Given this list of marker genes CARD8, SIRPD, NUCB1, ATP10D, FAM72D, CDKN1A, ESRRA, ZNG1B, ANXA5, RNF19B, RNU7-45P, LRRCC1, TMEM229B, HTATIP2, PTGES3P1, CATSPERG, GLRX, SLA, NLRP3 (NCBI Gene Id 9558), AKR1A1, WSB2, AP1M2, PARP4P2 (poly(ADP-ribose) polymerase family member 4 pseudogene 2), JMJD1C, TMEM51, MXD3, ADGRE5, TCAF2, MBD2, HAUS4, NTNG2, CARD6, EPSTI1, MIX23P1, ADAP2, GK3, SLC7A7, STARD8, CD14, SCML1, TM9SF2, CREM, ST8SIA3, FZD5, LILRA5, TMEM59, CLASRP, GRIN3A, CNTLN, MIR4632, NSL1, ARSL (arylsulfatase L), USP15, CLEC2B, FAM72A, PDK3, CYBB (cytochrome b-245 beta chain), SERPING1, DNM1P33, OR56B1, INTS3, SIK3, SIL1, AFF2, ERAP2, NGFR, STX4, SLC22A16, CALR, HERC6, DUSP10, EPB41L3, KIF9-AS1, OR52V1P, RMC1, NUCB1-AS1, STAM2, STOM, MED28, NT5C2, CICP19, FGL2, COPG1, NEU1, SH3BGRL, SCYL3, SLC31A2, STN1, MIR4433A, RAB43, NMT1, NIT1, TMEM154 (transmembrane protein 154), RNF13, CD68 (NCBI Gene Id 968), SPAG6, ISOC2, GAS6, MYL12A, PRPF4, TMEM140, SRA1, XAF1, MIIP, DLEU2, PLSCR1, FAM20C, TAB3-AS2, ACSM1, RUFY3, PML, ZSCAN16, OSMR, MCL1 (NCBI Gene Id 4170), MBOAT1, EGLN1, PAEP, MITD1, MAX, NECAP1, C1GALT1, SLC52A2, ASGR1, SYNGR2, PPP4C, SHOC2, NT5C3AP1, BACH1-IT2, LILRA6, MCTP1, CD33, IFNGR2, RAB39A (RAB39A, member RAS oncogene family), CTSL, DDX60, BCL10, CD300A, ARAP2, CHSY1, UBE2D3, RNF138, PRPS2, SLC22A1 (NCBI Gene Id 6580), RPL7P53, SLC1A3, C21orf91, FBXO6, KCNJ2, CXCL16, STX17, MR1, CD86, POLDIP3, HSPA7 (heat shock protein family A (Hsp70) member 7 (pseudogene)), TOMM40L, SLC44A4, DIP2B, CXCR1, TBK1, PTPRU, NKIRAS2, UBQLN4P1, TMEM131, SLC37A1, PLEKHA2, SLC17A8, PHF11, JUNB, TFE3, FHIP2A, TNFSF15 (TNF superfamily member 15), MTND4P14, NBN, RAB20, SLC43A2, OR2W6P, KIAA0319L, LSP1, SLC25A24, MGAT1, IFIT1, HMOX1, SHISA5, SPATS2L, ICAM2, RPS19P3, PLAGL2, WDFY1, CPED1, IFI44, EIF4E3, TLR3, ARMCX3-AS1, GRB2, OSTM1, ARPC1B, HNRNPA1P53, FAM225B, PHACTR2, BCL2L14, BRCA2, ERV3-1, FCGR2C, UBE2SP1, CD59, GOLM1, FTL, HES4, KCTD5, OGFR, CENPCP1, TGIF2, HK1, AAMP (NCBI Gene Id 14, angio associated migratory cell protein), MIA3, SIGLEC5, AKIRIN2, WSB1, CIR1, TIGAR, IL27, CARD17P, CEACAM1, DNAJC7, TMEM164, CARD16, ISG15, HMGB1P3, GPR42, MEGF11, GPX1, SPHK1, EIF2AK2, SNX11, LYRM1, UNC93B7, KCNMB1, USP6NL, VCAN-AS1, RGS19, PLXNB2, CDC73, SMARCD3 (SWI/SNF related, matrix associated, actin dependent regulator of chromatin, subfamily d, member 3), TOR1A, FGR, SIGLEC11, P2RX4, CHMP1A, SNORD56B, SAMD15, PSTPIP2, RTCB, TEP1, NMI, HNRNPLL, LRRK2, SH2D3C, RNVU1-1, REEP3, ALDH2, SH3RF1, CXCL9, SYNPO2, OOSP1, MNDA, LINC00528, OR7E100P, RNU5A-5P, SH3GLB1, JSRP1, QKI, IFI35, PRPF40A, IRF1, DPRXP2, B2M, C5orf58, IL17RC, BAZ2A, LAMP3, LAP3P2, SBNO2, ANXA2P2, TTC38, SLC5A9, MVB12A (multivesicular body subunit 12A), ELMO2, NT5C3A, DENND1A, C2orf66, CXCL11, MICA (NCBI Gene Id 92319), CIBAR1, MX2, WDR45, GUCY1A1 (guanylate cyclase 1 soluble subunit alpha 1), LMO2, RILPL2, CD300LF, SCARNA22, UBR2, PLEKHM2, AGBL5, SMIM10, ZNF804A, FGF13 (fibroblast growth factor 13), CDH6, PFKP, PIM2 (Pim-2 proto-oncogene, serine/threonine kinase), CCDC149, PTPN6, ZNF366, LTBR, IRF8, SRD5A1 (steroid 5 alpha-reductase 1), RCC2, DOCK8-AS1, TLR2, LINC00937, H3P6, CHMP2A, LPIN2, ANKRD36BP1, ZNF618, SLC2A3P2, SLC49A3, BIN2, SRGAP2C, PHLPP1, DMXL2, LINC00487, TCIRG1, SLC22A15, RNH1, TRIM44, SAMD9L, TMEM123, CLEC5A, SP100, KLF5 (KLF transcription factor 5), TNF, SUCNR1, RPS6KA4, CTSA, HCP5, ZDHHC5, NLN, IDH3G, RTL5 (NCBI Gene Id 340526), IFNK, CD1D, C2orf80, DERL1, TREX1, MAPKAPK3, ERICH6B, RCBTB2P1, PDIA6, ANXA4 (annexin A4), FEM1C, CSNK1G2, TAF8, DCLRE1C, RIPK1, TIPARP, CADM4, C6orf62, OR52H1, GBP4, JUND, TCF7L2, CYTOR, SLC27A3, EFCAB2, NCF1, NOD1, TMEM179B, APOBEC3G, ATP1B1, C5, OR52U1P (NCBI Gene Id 81243), AOAH, IFT56, RAB3GAP1, KMO, ARRB2, FMR1, MYCBP2-AS1, DUSP5, GIMAP6, TPM4P1, C1QB, CSF2RB, NAPA (NSF attachment protein alpha), TNFSF10, GORASP1, CYB5R4, FCN1, NCF1B, BATF2, IRF7, PSMB8, NRDC, MPEG1, HLX, IREB2, RAB10, CUL1, RHBDL2, PLSCR4 (NCBI Gene Id 57088), RN7SL124P, TRIM64EP, ANKRD22, FUOM, TIPRL, ZBTB7B, APOL3, KCNE3 (NCBI Gene Id 10008), DHRS12, ZNF496, UBE2L3, ARL11, DDX60L, CD74, TNFRSF1A, PELI1, CACNA1E, UNC93B1, CAST, AIM2 (NCBI Gene Id 9447), C1GALT1C1, OR52T1P, KLF4, EDEM2, ATP5F1B, PRKCE, LARP4B, CIMAP1B, LIPM, IFITM3, CYRIB, GM2A, GNG5, MSRB1, CCDC170, PLA2G7, RPS6KA5, TRIM69, CMTM6, SLIT2, ZNF702P, RPL5P23, RCN1P2, PARP10, UBQLNL, MT2A, FCGR2A, AGRN, FUNDC2P4, UBE2V1P6, EIF5A, MIR5685, TUBA1A, FAM241A, RPL37P1 (NCBI Gene Id 140696), MIDN, SIPA1L1, ATXN7L3, STAT2 (NCBI Gene Id 6773), GSN, OSBPL5, RN7SL368P, PRR16, SLC43A3, GCNT2, PRELID1, KLHDC8B, FAM72C, PLAC8, SH2B2, MPZL1, LIMK1, ANKUB1, SETP11, SCIMP (NCBI Gene Id 388325), KRT18P4, NETO2, SLC26A8, RPS6KC1, SLC22A4, HBG2, SIPA1L2, TMOD2, PSEN2, PSMA4, ADPRS, GK, ATP6V0E1, RFX5, RHOQ, IL12RB1, FCGR3A, ACLY, TLR4, TOX4, FMNL2, VWA3B, CERS6-AS1, RNA5SP201, IRF9, PKN2, CHN2, RIF1, BTN3A3, TMEM106A, MYOF, LPCAT2, MOV10, PSENEN, ZNF684, H2BC18, BLTP1, IL1RN, CEBPB, PIP5K1A, DHRSX, NFIL3, SCO2, ATP6V1E1, NIPA2, DDAH2, BAK1P1, NIBAN2, STK3, LMNB1, PLAAT4, ALPK1, NPC2, PTK2B, DECR1, GRAMD1B, YKT6 (YKT6 v-SNARE homolog), GNB4, PLA2G4C, MTMR4, TMX1, RNU6-890P, CFB, SAT1, AIF1, BTN3A2, STX10, DDX21, RALB, C3orf38, SORT1, NCF1C, CLK3, BAK1, PRKCD, CEP162, RN7SL600P, EIF4H, CASP7, MXD1, LACC1, DPF2, POLB, PSMA5, POMP, SYCE3, NRAS, HDX, LYZ, GUCY2F, CBR1, RNU7-40P, RRAS, RELT, ILK, LCP2, HPS5, ARCN1, BRD7, PRDM1, TNFSF13B, H3-3B, TRIM6, CCL8, RIPK3, SCO1, IL12A, IFIH1, GPS2, PTPN1, KPNB1, CD46, DNAAF1, ENDOU, AOAH-IT1, ADAR, APOL1, DNAJC15, LHFPL3-AS1, RAB11FIP4, BMAL2, TNFAIP2, ARHGAP26, MIR103A2 (NCBI Gene Id 406896), H3-5, OAS2, ERAP1, LY6E, REC8, ATF3, SH2B3, RNU4-41P, SCAMP2, GAPDHP14, MTMR14, AP2S1, TMEM219, TIMM10, SOCS1, PDIA3, HLA-H, FAM120A, RIGI, ATP6V1C2, MAPK14, WARS1, ZNF117, XPNPEP1, GNA13, SRC, TBC1D1, DZIP1L, FYTTD1, HLA-DRB1, CYLD, TSPAN17, NDUFA9, LGALSL, DNPEP (aspartyl aminopeptidase), CYTH4, NIPSNAP3A, ACO1, ZNF710 (NCBI Gene Id 374655), RN7SL435P, C3, C3AR1, STAB1, MFSD2A, CAPNS2, SMIM14, ZNRF2, TAFA2, SASH1, HAPLN3, H1-6, RAP1AP, MAN1A1, SAP18, RNF24, FMR1-IT1, H4C14, MIR142, AP1S3, TLDC2, SLC6A12, PLET1, SERPINB9, TOR1B, RSPH3, SNAPIN, DNAJB12, PIK3AP1, CASP4, TRAPPC3, MIR1827, RPL28, TSPAN2, RNU6-613P, RNA5SP449, CDK17, SCARB2, MOB1A, EXT1, CYFIP1, CMKLR1, RN7SL440P, GBP3, GRIPAP1, SPATA13, GNS, IFI27, TMEM268, ORMDL2 (NCBI Gene Id 94102), FLVCR1, DDO, STAT3, KARS1, RALY, PRLR, FRMD3, MIR4679-2, NDC80, FAR2, SQLE, PI4K2B, AFF1, KIF13A, ATP6V1B2, TMEM144, IRF5, HHEX, NAT8, AGPAT3, MIR4645, CFP, STYXL1, DEGS1, ARF1, SIGLEC14, TYROBP, ELF1, STAT1, IDH1, RBBP6, PPARGC1B, ETV6, RBMS2, HLA-A, MTND5P14, IFIT2, TMEM252, DNAJA1, MS4A14, VRK2, UQCRC1, ITPRIP, PSMB4, C15orf39 (NCBI Gene Id 56905), RBM43, LYPD5, BRI3, CHRNB1, SECTM1, SCARF1, SDE2, ABCA1, FANCA, RAP2C, CD209, DUSP3, ADAMTSL4, MTND1P11, METTL4, SEMA4A, CMC2, RN7SL364P, UBE2J1, MRPS21P2, SPATA1, USP25, USP2, RTN1, FAM225A, PRRG1, CHRNA6, CCNA1, ATOSB, MAP3K11, SLC51A, JAK2, DDX10P1, GASK1B, FNIP2, CHD1, PRRG4, RP1L1, ARHGEF10L, MTF1, ERICH3, BTN3A1, FCN2, RAB8B, DEK, GTPBP2, ARR3, PSMB2 (NCBI Gene Id 5690), CHRNB2, PIK3CD-AS1, RN7SL473P, HSPA8P5, SERTAD3, KIAA0040, MIR320E, BLVRA, CLIC1, TRIM56, KIAA0930, CYBA (NCBI Gene Id 1535), NRN1, TBC1D22A, FLOT1, VASP, NRBF2P4, RCSD1 (RCSD domain containing 1), YME1L1, SMAD1, LGALS17A, GIMAP4, SUPT4H1, SUSD1, WASHC4, DAPP1, FAS, EPHB1, NPTN, GVINP1, RAB8A, IDH3A, SELL, CLIC4, TOP1, EXOC6, FZD2, RNF185-AS1, ZBED1, NRBF2, PPM1K, SLU7, COMMD9, RAC1, BACH1, GIMAP2, MPV17L2, RBBP8, PSMD3, FOXN3-AS1, SCPEP1, MFSD14B (major facilitator superfamily domain containing 14B), TIMELESS, SYT9, STK40, CHGA, MTG2, NUP205, MOB3C, PRKAR1A, NXT2, IDH2, UPF3AP3, EVI2B, TNS3, DNAJC1, RTN2, RIN2, MTHFD2, SQSTM1, ZBP1, SAMD4A, SLFN5, LIF, FGD6, WASHC2C, ASPHD2, SLC25A28, PRELID1P1, PARP14, RCN1, RERE, ARHGAP27, DYNLT1 (dynein light chain Tctex-type 1), ADM (adrenomedullin), SFT2D2, PTGR1, NDUFV1-DT, PPP2R2A, NCKAP1L, KIF1C, HLA-DPA1, ACOD1, PHC2, CPPED1, MAP3K13, FPR2, RNF135, RNASE2, DNAJB11, DRAP1, VPS9D1, UBFD1, NAMPT, SNX10, PANX1, LMTK2, CELF2-AS1, CTSB, RO60, DPYS, IGSF6, ANXA3, MAT2B, SIGLEC16, MED12L (NCBI Gene Id 57726), PABIR3, RPL3P6, ARK2N, CLEC4D, DESI1, LIPK, KCNE5, ITPRID2, OSM, CCL13, IDO1, RNF144A, COQ10B, CHMP2B, WDR41 (WD repeat domain 41), SH3TC1, SLC35A4, EWSR1, SMCO4, WDFY3, BTN2A2 (NCBI Gene Id 10385), NASP, MARS1, RHBDF2, PRTG, DISC1-IT1 (NCBI Gene Id 104472714), THA1P, STAC3, RNU6-810P, C1QA, TATDN2P2, TXLNB, ADA2, SLC35A5, PRCP, SFT2D1, ZSWIM6, TGM2, PLXDC2, PSME1, DTNBP1, IL31RA, GRN, MLKL, DHX58, VRK3, PSMB9 (NCBI Gene Id 92051), ZNF438, TRIM26, TCN2, MTMR11 (NCBI Gene Id 10903), SP110, RHOT1, LIMK2, ANXA2, STK24-AS1, INAFM1, SCLT1, DRAM1, MIER1, SDC3, CYP2J2, TFG, NUB1, ETV7, OTUD5, DLC1, FYB1, CLCN5, GDI2, IGF2BP3, HCK, LINC00623, FNDC3A, GARIN4, FIG4, TAGAP, ANXA10, GBA1, HSPA6, SERPINB1, SP1, FAM20A, LILRB4, BAZ1A (bromodomain adjacent to zinc finger domain 1A), CCDC73, MIR4511, AIG1, PCGF5, CCSER1, CDKL5, CTRL, CES1, PRMT5-AS1, HIGD2A, JPX, TIMM17B, MTHFD1 (NCBI Gene Id 4522), UBTFL3, SNF8, TNFAIP6, GBP1P1, IL2RG, PDE4B, USP41P, ALDH1A1, EMP3 (epithelial membrane protein 3 (MAM blood group)), TMEM62, NCOA3, CNTD1, IL15, ADCY7, FUT4, PRDM5, ACTR1A, GAK, OR10AA1P, CLDN18, PMAIP1, CCDC97, PLEKHN1, HBP1, KREMEN1, ZNF672, PARP9, ACSL4, C14orf93, IFI44L, SLAMF8, PSMA6, NRIP1, SNX20, HSPB9, IFIT5, CD36, MIR4435-2HG (MIR4435-2 host gene), LOXL3, SCRN3, ACOT9, PRR11, LHFPL2, CYC1, AGPAT5, VDR, CHMP4B, RBM7, TXNIP, CFAP58, LILRB5, ABCD1, GPD2, DPYD-AS1, ACSL5, TJP2, KDM1B, COPE, HTR4, TFEC, EXOSC9, CYBC1, ARFIP1, GRK3, NUP58, MFSD14A, WDFY3-AS1, C9orf72, TINF2, SLC31A1, CFLAR-AS1, ZEB2, GPR141, NADK, COP1, SPART, SLC12A8, CLEC7A (C-type lectin domain containing 7A, NCBI Gene Id 64581), NHSL1, P2RY12, ERP29, PSMD6-AS2, LOXHD1, XIAP, EXOC3L1, PRR29, MANBAL, CERKL, WASHC2A, DCAF11, ANO5, CPVL, LINC00534, ATG3, RNU4-24P, CD38, UTRN, MX1, ATP6V0D1, C19orf38, BATF3, NCEH1 (NCBI Gene Id 57552), BNIP5, RASGRP3, DOK1, LINC00877, SNX6, TXN2, GLUL, ADPGK-AS1, KIF1B, GBP1, IFITM2, BIN3, EFHD2, CDH23, CCRL2, DYSF, DDX3X, SMAP2, TPP1, SLFN12, CDKN2D (NCBI Gene Id 1032), ZNG1C, PRMT5, SRBD1, MSL3, CMAHP, AMER1, HK3 (NCBI Gene Id 3101), SNTB1, LMO4, PRKAG2, STOML1, SDSL (NCBI Gene Id 113675), GPBAR1 (NCBI Gene Id 151306), FLI1, CLCN7, MICALL1, HERC5, ORAI2, ICAM1, NLK (nemo like kinase), PANK2, PARP4, DHX8, VAV1, UBE2F, SRP54, PBLD, CBX1P4, HLA-G, RSPH9, CALM3, PLPBP, SSB, PDCD1LG2 (programmed cell death 1 ligand 2), APLP1, MAGT1, NABP1, PLSCR2, ZFP36 (ZFP36 ring finger protein), LGALS1, MDK, GIMAP8, GPBP1, MILR1, BMPR2, RAB1A, ZNFX1, TAPBP, SOWAHD, SLC25A30, TPM3 (tropomyosin 3), RAB33B, EDEM1, MTND6P5, GMFBP1, ZCCHC2, CACNA1A, NFE2L3, JAK3, PPTC7, TAP2, PRKD2, H4C15, STARD4, NINJ2 (ninjurin 2), SESTD1, FKBP15, UBE2E1, USP18, IRAK2, ROGDI (NCBI Gene Id 79641), CD163, TMEM165, CD2AP, PAIP1P1, HELZ2, MS4A4A, SLC16A3, EPS15, FAM111A, CAPZA2, PNPT1, RASSF5, COA6, HLA-C (NCBI Gene Id 5674), N4BP1, SCYL2, BTK, NOD2, GK-AS1, CHST7, RAB12, EMILIN2, PRUNE2, ZNG1F, RAB5A, NCOA2, STK32B, MS4A7, JUP, EPG5, UBA7, CENPN, SP140, CPEB3, BECN1, HSH2D, OR52K1, TENT5A, NAGK, SPG11, PLS3, TOPORS, LRRC59, NLRC4, H2AC6, IL1B, H3P36, ACP2, MIR3150B, ITGA4, DBF4B, HAVCR2, FAM135A, NME8, ST8SIA4, DHTKD1, SPG21, GCH1, CNIH4, HSPA1B, CCR1, CD300E, RNY4P18, SCIN, HIF1A, SDHB, GTPBP1, SUMO1P4 (NCBI Gene Id 101290502), IFIT1P1, PPCDC, KLHL6, LYN, ZC3HAV1, FOXD4L4, ATP6V1G1, NAPSB, MIR4477A, CDKN1C, NANS, HCG27, STX3, TBC1D20, OR52K2, TNFRSF14, DPYD-AS2, NUP62, SCAF11, CTSZ, BBX, TRIM38, KCNH7, USP30, EHD4, OTUD4P1, MTPN, RUBCN, EFR3A, TMEM150B, FOXL2, GPR84, HBEGF, RNU6-1294P, ARSD, KCTD14, PSMC1P4, PTTG1IP, DAZAP2, ADCY4, NUDT16, APOL4, MED13, NFAM1, IFI30, APOL2, FRMD4B, GPR155, PLEKHB2, HIRA, MRPL44, VSIR, CCDC200, KIF5B, GNA15, KDM2A, C5orf15, OR52B4, ARHGAP31, RNF31, TBC1D2B, IFI6, ATXN7, RN7SL382P, CES1P1, RN7SKP17, NFKBIA (NFKB inhibitor alpha), HLA-DPB1, ILRUN, CARS1, SAMHD1, CYB561, IER5, TTC21A, FCGR1BP, TRPC4AP, KCNS2, PEF1, LAG3, UBE2L6, TMEM199, FARP2, ME2, BID, MFSD5, ARSB (arylsulfatase B, NCBI Gene Id 411), ISG20, CDC42EP2 (NCBI Gene Id 10435), MTND5P28, H2BP1, RESF1, ASPRV1, TAF10, KBTBD2, CIITA, KIAA1958, IDO2, CXCL10, FOXN2, HEBP1, PHF23, TMOD3, RNASEL, MSR1, VAMP3, GALM, PLEK, PCK2, TRAFD1, CD300C, TGM1, MRPS18A, ZDHHC4P1, BTN2A3P, GNB2, TATDN3, EYA1, CAPZA1, C19orf12, GYG1, SMTNL1, CCL1, PAK1, CST3, POLA2, SIK1, SETD7, RAB5C, NFKBIE, COPZ1, TOR1AIP1, MAD2L1BP, RNU6-1082P, FCGR1A, ELOVL5, MATCAP1, LAT2, NOP10, TIFA, OASL, GART, SAMD9, TMED7, CCDC154, COX6B1, NAGA, PBX2, CNP, VMP1, RNF114, FAM8A1, PIPSL, TUT7, GCNT1, SIGLEC1, EMP1, HSPA1A, SEC24D, LAMP2, GLIPR2, STS, RIPOR2, PTPA, CLEC4E, KANSL1L, SERTAD1, GABARAP, VAMP5, PIGB, APOBEC3B, CMPK2 (NCBI Gene Id 129607), SLK, IER2, OAS3, HESX1 (HESX homeobox 1), ZNG1E, THEMIS2, SNORA51, LIFR, CALHM6, FAP (fibroblast activation protein alpha), MSRB2, TASL, CD53 (NCBI Gene Id 963), ECPAS, LILRA1, DTX3L, PPP1R11, DISC1, TNFAIP3, OR52K3P, TRIM27, HLA-K, AURKAIP1, ADPGK, TRIM22, IL17RD, ZMYM4-AS1, MT-TS1 (mitochondrially encoded tRNA-Ser (UCN) 1), WDR64, STAT5A (NCBI Gene Id 6776), SLITRK4, CLEC1A, SRGAP2-AS1, RNASEH2B, FIBP (NCBI Gene Id 9158), CCDC9, RNASEH2B-AS1, RANGAP1, TBC1D8, TESK2, TMSB10, STARD3, MRPL17, SH3BP2, GSTK1, DNTTIP1, ARHGAP25, PTP4A1, MAP2K6, ATF5, SRGAP2B, HIVEP1, GBP6, DHRS9, CNTRL, ST3GAL5, SFRP1, CYSTM1, RHOG, PSMA3, LSM10, KYNU, DEDD2, FFAR2, PLIN3, CALM2P2, ZNF267, IFI16, CHMP5 (charged multivesicular body protein 5), CORO1B, UNC93B2, KAT5, ATF6, TANK, HELB, MS4A6A (NCBI Gene Id 64231), CAPN2, GTF2F1, RMI2, GMPR2, PIWIL4, ABHD16A, CASP5, IL13RA1, CGAS, RBCK1, CICP3, RTP4, APOL6, BROX, UBE2S, DIAPH2, RTEL1P1, RNF169, ECE1, HLA-DMB, FOLR2, MYCBP2, STAU1, PTPRE, LAPTM4A, PRDX1, LDLR, KCNJ15, ADPRH, CSF1R, STIMATE, MPDU1, RNA5SP39, CCL2, TRIM25, ZDHHC19, DOCK4, SLC37A2, CEP164, CCDC146, SETX, AP3B1, CTBS, CREBRF, TAP1, YIPF1, SASH3, RNU6-147P, SLC44A2, RSAD2, HLA-B, ZC3H12A, LMF2, EIF4A1P7, PTGS2, LGALS9, TMEM121B, PLAGL1, RN7SL587P, CAMK2D, CTNNA1, P2RY13, RELB, RAB24, UBE2CP1, ATP1B3, CCL7, DLEU7, MRPL16, SCG3, PSAP, USP30-AS1, SPSB1, ZDHHC18, CASP1, SQOR, SHOX2, MFSD13A, UBN1, PUS3, DUSP1, VCPIP1, IFITM1, LINC00968, LGALS3BP, LATS2, GK-IT1, MEFV, CFAP58-DT, GSDMC, TMEM30A, SLC9A8, RNU6-748P, CARINH, NAB1, SERPINA1, IGHE, CPB1, HSPA5, TRIM5 (tripartite motif containing 5), FAM120AOS, FBXL5, MYD88, PATL1, MAP3K8, AKAP13, CASP1P2, ST3GAL2, RN7SL105P, GCA, CNDP2, HLA-F, RPAP3, HNRNPF, SLC15A3, SNX2, RNA5SP237, RNU1-100P, GSDMD (gasdermin D), GAB2 (NCBI Gene Id 9846), ARPC3, PFKFB4, MUC1, UNC93B8, DPYSL2, RUFY4, SART1 (spliceosome associated factor 1, recruiter of U4/U6.U5 tri-snRNP), FGD2, AP1S2, CYP4A22-AS1, HLA-DMA, SNORA11B, IL4I1, APOBEC3C, TRIP12, RRM2B, ARHGEF3, ITM2B, LLPH, PLCL2-AS1, CTSS, FAM91A1, LGALS8, HINT3, FCGR3B, EHBP1L1, DPP3 (NCBI Gene Id 10072), DCBLD1, STK24, HEXD, CEP15, DUSP6, AP3D1, ABHD3, MICB, RTF2, XXYLT1-AS2, FBXO39, LGSN, PLEKHO1, AP5B1, SNX17, GAB1, HADHB, TLR7, RP2, PRICKLE1, SOBP, NLRC5, PYCARD, RB1, USP19, ARL5B, CPEB2, C2, FOXC1, IFIT3, SLC8A1, ARPC5, CCL25, ATP1A4, LARP1, ARID4B, LACTB, BACH1-AS1, LILRB1, FUCA2, USP42, PLA2G4A, HORMAD1, TMEM60, CSF3R, FLVCR2, DNM1P34, BCL3, FAM72B, B4GALT5, EXOC3L4, ZEB2-AS1, TICAM2, HNRNPH2, TMEM33, PEA15, RXFP1, ZNG1A, GTF2B, TUBA1B, MAP3K5, SLFN11, CLEC6A, GSTO1, PSMB10, CCR2, CD274, PDLIM5, RGS1, EIF4G3, APOBEC3B-AS1, ZNF200, HERPUD2, APOBEC3F, MIR601, LINC00582, ACSL3, SHFL, CFLAR, MARCO, DNAJC13, MAFB, REL, ENPP2, PSME2, ACER3, SBF2, LPP, LYSMD2, NHLRC3, NFKBIZ, THOC7, MTND4P26, ERP44, DIPK2A (divergent protein kinase domain 2A), BST2, TNFRSF1B, TM9SF4, TLR1, KPTN, FAM120A2P, RN7SL168P, USPL1, TRPV4, ITPK1, STX12, MAP3K7CL, SOD2, PSEN1, HCAR2, ATP8A2P2, ABTB2, RBM23, OR52P2P, ACTR3, APOBEC3A, MIR4773-1, FCER1G, TLE4, UBE2Z, SRGN, PGAP1, RBM47, SCUBE2, TLR8, APH1A, ARAP1-AS1 (NCBI Gene Id 100874075), PTPRC, SPTLC2, SSTR3, CTCFL, BIRC6-AS1, DCLRE1CP1, APOBR, DCP1A, IRF2 (interferon regulatory factor 2), RAB43P1, GBP2, BTN2A1 (butyrophilin subfamily 2 member A1), FFAR3, ADAMTSL4-AS1, EPHB2, PTPRO, DEFB1, MIR3671, TNK2 (tyrosine kinase non receptor 2), SMG7-AS1, SP140L, EIF4A1P2, AMBRA1, PADI6, NBR1, GLA, SLC39A1, HLA-DRA, CD40, SMCHD1 (NCBI Gene Id 2490), ASGR2, RNF149, CXorf38, RICTOR, HLA-J, GALNT3, RNF217, BRMS1, AIDA, CREG1, C4orf3, ELF4, MICU1, CXCR2P1, CLCN4, USF1, SLC6A13, DPYD, NCOA7, MARCKS, SLAMF7, CDHR5, MASTL, STX11, AK4, HSPA8, RGL1, ACSL1, NR1I3, RARA, PSMB3, NECAP2, IGHEP2, XRN1, PISD, TYMP, HIVEP2, MVP, HSPD1P6, CARS2, RNF185, FOXD4L5, CTSH, TPMT, DCUN1D3, GBP5, HLA-E, HSD17B11, GOLGA5P1, TRANK1, TRIM21, COL9A1, USP33, COX5B, NINJ1, KLHDC7B, COL8A2, UBE2D1, CASP10, ITPRIPL2, FANCL, N4BP2L2, CYSLTR1, LINC00189 (long intergenic non-protein coding RNA 189), NEXN, SNN, C1orf162, MEF2A, HPSE, P2RY6, TDRD7, ARL8B, SIAH2-AS1, DOCK8 (dedicator of cytokinesis 8), PCBP1-AS1, SPPL2A, CAPG, KCNJ2-AS1, NCF2, SLC20A1, FCGR2B, OTOF, LCP1, PSMA2 (NCBI Gene Id 5683), NSF, RN7SKP26, OS9, ABI1, ITPK1-AS1, GADD45B, COTL1, C4orf33, NDUFB6, CSRNP1, NRBF2P3, ACTA2, KCTD12, LIPA, ANKRD13A, PPL, TRIM14, TAPBPL, INMT, ATG16L2, CTSO, CD164, OR51R1P, SRGAP2, RHOQP3, ASCL2, EPAS1 (NCBI Gene Id 2034), TMEM255A, TMUB2, TOX4P1, BLZF1, RIC1, PARP12, PLEKHO2, GNB1, SLC2A6, TXNL4B, MORC3, MIR3145, CDC42EP4, CMTR1, DGLUCY, RNF213, DDIAS, RN7SL834P, GAS8, RIPK2, RAC1P2 (Rac family small GTPase 1 pseudogene 2), AZI2, TMEM185B, MTMR6, H2BC21, IMPDH1P10, KCNMA1, SAT2, ZFYVE26, LAP3, PLAUR, NCSTN, RPS2P44, MPZL2, LILRB3 (leukocyte immunoglobulin like receptor B3), GPR65, P2RY14, GBP7, LILRB2, NFKB2, PARP11, ARPC4, P2RX7, CCNL1, KY, IL15RA, OAS1, RAB31, LONRF1, HCAR3, ERI1, TRIM34, RASGEF1B, ANKFY1, SHTN1, SZRD1 (SUZ RNA binding domain containing 1), DENND5A, TMEM50A, CALCOCO2, N4BP2L1, H3-3A, PKD2L1, here is a description of the gene set: Human Gene Set: OSMAN_BLOOD_CHAD63_KH_AGE_18_50YO_HIGH_DOSE_SUBJECTS_24HR_UP BACKGROUND: Visceral leishmaniasis (VL or kala azar) is the most serious form of human leishmaniasis, responsible for over 20,000 deaths annually, and post kala azar dermal leishmaniasis (PKDL) is a stigmatizing skin condition that often occurs in patients after successful treatment for VL. Lack of effective or appropriately targeted cell mediated immunity, including CD8+ T cell responses, underlies the progression of VL and progression to PKDL, and can limit the therapeutic efficacy of anti-leishmanial drugs. Hence, in addition to the need for prophylactic vaccines against leishmaniasis, the development of therapeutic vaccines for use alone or in combined immuno-chemotherapy has been identified as an unmet clinical need. Here, we report the first clinical trial of a third-generation leishmaniasis vaccine, developed intentionally to induce Leishmania-specific CD8+ T cells. METHODS: We conducted a first-in-human dose escalation Phase I trial in 20 healthy volunteers to assess the safety, tolerability and immunogenicity of a prime-only adenoviral vaccine for human VL and PKDL. ChAd63-KH is a replication defective simian adenovirus expressing a novel synthetic gene (KH) encoding two Leishmania proteins KMP-11 and HASPB. Uniquely, the latter was engineered to reflect repeat domain polymorphisms and arrangements identified from clinical isolates. We monitored innate immune responses by whole blood RNA-Seq and antigen specific CD8+ T cell responses by IFN-gamma ELISPOT and intracellular flow cytometry. FINDINGS: ChAd63-KH was safe at intramuscular doses of 1x1010 and 7.5x1010 vp. Whole blood transcriptomic profiling indicated that ChAd63-KH induced innate immune responses characterized by an interferon signature and the presence of activated dendritic cells. Broad and quantitatively robust CD8+ T cell responses were induced by vaccination in 100% (20/20) of vaccinated subjects. CONCLUSION: The results of this study support the further development of ChAd63-KH as a novel third generation vaccine for VL and PKDL. TRIAL: This clinical trial (LEISH1) was registered at EudraCT (2012-005596-14) and ISRCTN (07766359). from publication Osman M, Mistry A, Keding A, Gabe R, Cook E, Forrester S, Wiggins R, Di Marco S, Colloca S, Siani L, Cortese R, Smith DF, Aebischer T, Kaye PM, Lacey CJ (PMID 28498840) Genes up-regulated in blood 24hr vs 0hr in adults (18-50) (high dose subjects) after exposure to ChAd63-KH, time point 24H, administered Intramuscular injection. Comment: DE gene list for high dose subjects. species: Homo sapiens